The following is a description of a gene set: Genes down-regulated in comparison of untreated CD4 T cells at 0 h versus the cells treated with IL4 and anti-IL12 at 24 h. The aim of this dataset was to study in detail the transcription kinetics initiated by cytokine IL-4 in early differentiation of Th2 cells. Human Gene Set: GSE17974_CTRL_VS_ACT_IL4_AND_ANTI_IL12_24H_CD4_TCELL_DN studied in species Homo sapiens from publication Elo LL, Järvenpää H, Tuomela S, Raghav S, Ahlfors H, Laurila K, Gupta B, Lund RJ, Tahvanainen J, Hawkins RD, Oresic M, Lähdesmäki H, Rasool O, Rao KV, Aittokallio T, Lahesmaa R (PMID 20620947), and this is the list of marker genes: SND1, SMKR1, TBC1D1, TK1, MTCH2, ASPM, PAF1, RFC2, SLC39A14, PDHA1, MRPS33, CCDC124, SH2D2A, CHAF1B (chromatin assembly factor 1 subunit B), ECI1, PSMB2, RAD51AP1, ZNF367, LCMT2, ETFB, MRPL18, SCFD2, MTMR2, CCDC34, GPANK1, PHPT1, PSMD8, SFT2D1, SRPK1, NLE1, ZWILCH, MLYCD, GAR1, GOT2, PSMB10, ZMYM6, CDK5, THYN1, TUBE1, MTHFD1, HAUS7, PSMG1, SGCB, VRK1, POLE4, CREB3, SLC43A3, OGFOD2, MED20, MRPL23, POLR2F, INTS13, OARD1, ASNS, RUVBL2, EZH2, BCL2A1, RBM14, MCTS1, PRELID1, CCDC121, SNRNP25, CENPM, LTA, ZNF780A, MRPS18A, LRRC42, SDF2L1, MFAP1, MEA1, NIF3L1, ACY1, RCC1L, ATP1B3, IMPA2, RNGTT, EED, MED31, PAM, ARMC6, POLA2, MFSD4B, PPIL1, JAML, PPP1R14B, RNASEH2A, QDPR, TDP1, INTS2, MTX1, PI4K2B, CBR4, GLB1, HIRIP3, IFT56, MIR3142HG, ORC5, ZC3HAV1L, LSM4, NAA38 (N-alpha-acetyltransferase 38, NatC auxiliary subunit), ADISSP, WDHD1, SNRPG, TOMM5, ACTL6A, CCT6A, DESI1, BRIP1, DNAJA3, TPX2, NUP88, SLC37A4, HDDC3, WDR3 (WD repeat domain 3), MRPS28, CKS2, TMEM106C, COL6A3, DTYMK, CLPP, DCPS, FADD, PRDX1, SCCPDH, SUV39H2, ATP6V1A, MIPEP, ATOX1, TEDC2, CTPS1, GSTP1, RMI1, SLC25A43, FTSJ3, OR7E36P, TMEM126B, NIFK, WRAP53, RPP25, TBC1D19, DLC1, SF3B3, NAA10, UTP11, MTNAP1, COA3, CCNA2 (cyclin A2), PRDX4, BIRC5, TXNDC17, ARMT1, SLC25A15, ACAT1, CENPJ, CKS1B, GBP2, MRPL52, VPS25, RNF8, WDR36, ACAA2, SLC25A20, ERG28, NDC1, DNPH1, BMAL2, NUDCD1, TIMM50, ACOX1, MCM5, ZNF239, NUBP1, CKLF, TIPIN, FLAD1, SAP30, TUBB3, CENPS, STOML2, ZNF787, SLC7A1, ZW10, AIFM1, TMEM14A, MPLKIP, MRPL12, EFNA4, ATG7, TPRN, FEN1, DYM, LMNB1, PRIM1, TBL2, SLC19A1, PAICS, MTFMT, PHF19, WSB2, DCLRE1B